Given this list of marker genes GPM6B, DYNC1I1, PICALM, LIN52, PTPN22, TMEM132E-DT, SLC39A3, MDH1B, CASP14, RIMBP2, CXCL12, NALF1, TRAF6, USF3, SNAP29, XRN1, INO80D, SPOCK1, EEF2K, DGKI, WAS, KCNJ6, LPAR3, CPM, TRIM5, SYNRG, TGS1, TOR1B, ZNF34, JMJD1C, CA13, STOX2, ARHGDIA, RNF114, CLCN5, SLC5A3, ASH2L, OLA1, MDM4 (NCBI Gene Id 4194), FCAMR (NCBI Gene Id 83953), BCL11A, VAPB, SUSD5, DCK, NFATC4, ABHD18, GPR65, DMRTC1B, ADH1B, RASGRP1, KLHL26, ARHGEF39, CD93, DUXA, MSN, DSC2, CASK, MCPH1, HHEX, CSMD2, ASTN2 (NCBI Gene Id 23245), CALCRL, PIP4K2C, NTS, EYA3, DHX15, IPO7, SQSTM1, LDLRAD1, DCAF11, TUT4, BSN, KRT73, LPAR1, MTCL2 (NCBI Gene Id 90072), INSM2, ADPRM, EPB41L1, TRAPPC2, UBE2S, PRSS16, CLASP2, FKBP14, AAK1, TNRC6B, HLA-B, GDAP1L1, MRGPRX2, ZNF706, CXCL11, GTPBP1, NLGN1, GLTP, CHSY1, CDIN1, SLC24A2, AFDN, TTC19, UBL4A, PLEKHM3, HLA-A, C1GALT1, ADH7, ZMYM3, SGPP2, SPAG9, CNOT6L, ANAPC16, C3orf70, KCTD10, HERC5, ZDHHC3, ZNF623, S1PR1, ZNF614, SFXN4, STX6, HLA-C, KIN, ENGASE, CCDC15, CIP2A, ARID1A, FAM72C, EBF3, ZDHHC22, MFAP3, PLXNA2, ZC3H13, GPR158, SYT6, ATP6V0D2 (ATPase H+ transporting V0 subunit d2), BRSK2, NEUROG2, SLC12A3, CRYZ, SRRM4, MAP3K11, VSTM4, ERC1, NDRG4, EML4, KDSR, S100A7A, LYPLA2, ADM, MBNL1, STIP1, NR1D1, ACSL3, LINGO2, C14orf132, LPL, SRGAP2B, TRPV3, LAX1, SPRED2, TBX10, TPCN2, AWAT1, ASXL1, HECTD2, TOP2B, SERAC1, GPC4, LENG8, SBDS, PNISR, MGRN1, CCDC97, PDE6A, ORAI2, MSR1, SEL1L, ACE2, STIM1, AP1AR, APC, ARL4C, ZNF562, RUNX1T1, YPEL2, TNFSF8, NDUFA2, MAP1A, STK40, ZC4H2, DERL2, DNPEP, ZDHHC9 (zinc finger DHHC-type palmitoyltransferase 9), ICA1L, SLC35D1, SRXN1, CFLAR, TBC1D10B, AMOTL1, CDH10, CCDC50, CCDC32, MFF, TVP23B (trans-golgi network vesicle protein 23 homolog B), LAT2, FAM72D, NFIB, BORA, HEPACAM, MPZL2, ZNF711, ZNRF2, LGALS3, GALNT10, OTULIN, DYDC2, DDOST, ENSG00000255537 (novel transcript, antisense to FEZ1), MYO18A, ADAMTS2, DMRTC1, NME6, YWHAG, ASH1L, ZNF621 (NCBI Gene Id 285268), PRNP, RPL7L1, TEF, PPBP, ZNF844 (NCBI Gene Id 284391), IKZF3, RAB3B, ZNF662, ZNF630, GNG7, here is a description of the gene set: studied in species Homo sapiens from publication Chen Y, Wang X (PMID 31504780) Human Gene Set: MIR4524A_3P Genes predicted to be targets of miRBase v22 microRNA hsa-miR-4524a-3p in miRDB v6.0 with MirTarget v4 prediction scores > 80 (high confidence targets).